Given this list of marker genes Slfn2, Hbb-bs, Ccl9, Sirpa, Pacsin1, Lat2, Csf1r (colony stimulating factor 1 receptor), Zdhhc14, Ly86, Ctsb, Hsd11b1, Ablim1, Cd53, Pld4, Gp1bb, Hsd17b8, Papss2, Clec4a2, Rgs14, Col11a2, Rgs10, Kcnab2, Rnasek, Arg2, Ptprc (NCBI Gene Id 19264), Slc11a1, Reln, Cd68, Nhsl2, Itgb2, Ly6c1, Gria2, Rogdi, Ppp3ca, Prkcb, Rnf227, St3gal6, Stmn1 (NCBI Gene Id 16765), Cbx4, Mal, Abr, Bin1, Ap2a2, Cebpd, Hdc, Acvrl1, Adss1, Grina, Evi2a, Cma1, Tyrobp, Adgre1, Ncam1, B4galnt1 (beta-1,4-N-acetyl-galactosaminyl transferase 1), Lilrb4b, Mpeg1, Coro1a, Klra7, Cyfip2, Mllt11 (myeloid/lymphoid or mixed-lineage leukemia; translocated to, 11), Rflnb, Bmp1, Ctss, Evl, Gsn, Ppp2r5a, Cd47, Rbmx, Efhd1, Zap70, Gypa, Nin, Pglyrp1, Nrp1, Rtn3, here is a description of the gene set: Genes depleted in embryonic, neural and hematopoietic stem cells. The transcriptional profiles of mouse embryonic, neural, and hematopoietic stem cells were compared to define a genetic program for stem cells. A total of genes are enriched in all three types of stem cells, and several of these genes are clustered in the genome. When compared to differentiated cell types, stem cells express a significantly higher number of genes (represented by expressed sequence tags) whose functions are unknown. Embryonic and neural stem cells have many similarities at the transcriptional level. These results provide a foundation for a more detailed understanding of stem cell biology. Mouse Gene Set: RAMALHO_STEMNESS_DN from publication Ramalho-Santos M, Yoon S, Matsuzaki Y, Mulligan RC, Melton DA (PMID 12228720) species: Mus musculus